The following is a description of a gene set: studied in species Homo sapiens An abnormality of the Incisor tooth. Abnormality of the incisor Human Gene Set: HP_ABNORMALITY_OF_THE_INCISOR, and this is the list of marker genes: ARHGEF38, STIL, GJA1, CDH1, CNOT1, SUMO1, PPP1R13L, CKAP2L, ATR, IKBKG, CACNA1I, BLM, PLCH1, PTCH1 (NCBI Gene Id 8015), DLL1, STAG2 (NCBI Gene Id 10735), PACS2, DNMT3A, ST14, AXIN2, MID1, TGFA, ATP6V1B2, SHH, GLI1, DPH2, DYNC2LI1, SMC1A (NCBI Gene Id 8243), ABCC9, ADAMTS15, CTCF, TGIF1, NODAL, COBLL1, ATRX, EVC2, DLG1, DOCK7, GAS1, HRAS, ZIC2, B3GLCT (beta 3-glucosyltransferase), MSX1, WNT10A (NCBI Gene Id 93651), LRP6, CDH11 (cadherin 11), PRKACB, EP300, FGFR1 (NCBI Gene Id 84151), NAA80, KCNMA1, ERCC3, RIPK4, TP63, FGFR2 (fibroblast growth factor receptor 2), NEK1, CDON, PAX9, NHS, KAT6A, TUBGCP2, EIF4A3, EDARADD, BRD4 (bromodomain containing 4), CREBBP, PRKACA, EVC, SCUBE3 (signal peptide, CUB domain and EGF like domain containing 3), BMP4, GRIA3, CRIPTO, FGF8, CHSY1, CDC42BPB, STAG1, DLX3, SIX3, CCBE1, PDGFRA, FREM1, WNT10B, FARS2, ARHGAP29, TBC1D2B, HMGB3, BCOR, FOXH1, BRF1, EDA, ANKRD11, COL11A1, RIC1, RPS6KA3, NECTIN1 (nectin cell adhesion molecule 1), IRF6 (NCBI Gene Id 7452), TBC1D24, GATAD2B, VPS13B, SMAD2, ALX3, FGF3, GLI2, KCNK9 (NCBI Gene Id 51305), NAA10, DISP1, PURA, RNF2, DLX4, SUFU